The following is a description of a gene set: Breast cancer compendium: 100 transcription regulators showing most correlated expression with the 9 'embryonic stem cell' transcription factors that are preferentially and coordinately overexpressed in the high-grade, ER-negative breast cancer tumors. Cancer cells possess traits reminiscent of those ascribed to normal stem cells. It is unclear, however, whether these phenotypic similarities reflect the activity of common molecular pathways. Here, we analyze the enrichment patterns of gene sets associated with embryonic stem (ES) cell identity in the expression profiles of various human tumor types. We find that histologically poorly differentiated tumors show preferential overexpression of genes normally enriched in ES cells, combined with preferential repression of Polycomb-regulated genes. Moreover, activation targets of Nanog, Oct4, Sox2 and c-Myc are more frequently overexpressed in poorly differentiated tumors than in well-differentiated tumors. In breast cancers, this ES-like signature is associated with high-grade estrogen receptor (ER)-negative tumors, often of the basal-like subtype, and with poor clinical outcome. The ES signature is also present in poorly differentiated glioblastomas and bladder carcinomas. We identify a subset of ES cell-associated transcription regulators that are highly expressed in poorly differentiated tumors. Our results reveal a previously unknown link between genes associated with ES cell identity and the histopathological traits of tumors and support the possibility that these genes contribute to stem cell-like phenotypes shown by many tumors. species: Homo sapiens Human Gene Set: BENPORATH_ES_CORE_NINE_CORRELATED from publication Ben-Porath I, Thomson MW, Carey VJ, Ge R, Bell GW, Regev A, Weinberg RA (PMID 18443585), and this is the list of marker genes: HTATIP2, ATF4, ILF3, RUNX3, TBX19, PLAGL2, ID4, PNRC1, IRF1, KLF11, MAFG, TFDP2 (transcription factor Dp-2), SOX11, ETV7, RBL1, SOX9, FOXK2 (NCBI Gene Id 84213), DR1, MYBL2, TFAP2C (NCBI Gene Id 7022), SUPT5H, TAF2, CBFB, GTF2H4, MYC (MYC proto-oncogene, bHLH transcription factor), NFIL3, E2F3, FOXC1, CEBPB, ETV6, ZBTB5, NSD2, E2F1, TCF20, SOX4, MDFI, NMI, ELF5, BCL11A, NFKBIE, SRF, CALR, FOXM1, GATAD2A, ILF2, EN1, FOXG1, RELB, YEATS2, HIF1A, TFDP1, NFIB, SOX10, WWTR1 (WW domain containing transcription regulator 1), MLXIP (MLX interacting protein), CREB3L2, LMO4, WDHD1, HMGB2, TRIP13, SMARCA4, HSF1, CEBPG, MYBL1, KLF5 (KLF transcription factor 5), MYBBP1A, GATA6, NFE2L3, ELF4, TBPL1, SIX3, TLE1, TGIF2, TEAD4, PAX6, EED, VGLL1, DMRT1 (doublesex and mab-3 related transcription factor 1), KDM1A, E2F8, TFCP2L1 (transcription factor CP2 like 1), SPIB, HIVEP1, BCL11B, TCF7L1, SSRP1, HDAC2, MSL3, ZIC1 (Zic family member 1), STAT1, POLR1E, HMGB3, DEK, YBX1, EZH2, SAP30, HMGA1, VGLL4, GTF3C2 (general transcription factor IIIC subunit 2), MED8